The following is a description of a gene set: studied in species Homo sapiens Human Gene Set: GOBP_MRNA_TRANSPORT The directed movement of mRNA, messenger ribonucleic acid, into, out of or within a cell, or between cells, by means of some agent such as a transporter or pore., and this is the list of marker genes: NSUN2, FXR1, SARNP, NXF5, NUP160, SETD2, MX2, ZC3H11B, DDX25, NXT2, ALYREF, UPF3B, RANBP2, RAE1, NUP88, SMG6, LUZP4, NUP107, XPO1, SMG7, NDC1, UPF1, LRPPRC, PCID2, GLE1, RBM15B, EIF4A3, NXF2, FMR1, POLDIP3, NXF3, TNKS, AHCTF1, RANBP17, NUP85, DDX39B, IGF2BP1, HSF1, NUP54, NUP43, NUTF2, UPF3A (NCBI Gene Id 95832), POM121B, MAGOHB, KIF5C, NCBP1, SENP2, UPF2, NUP50, G3BP2 (G3BP stress granule assembly factor 2), PABPN1, DDX19A, ALKBH5, DHX9, SEH1L, THOC5, SEM1, NUP58, ZC3H3, NUP35, QKI, TPR, MVP, EIF4E, SMG5 (NCBI Gene Id 23381), NUP93, HNRNPA1, KHSRP, IWS1, RBM33, ZC3H11C, CETN2, NCBP2, FYTTD1, NUP214, NPIPA1, NXF2B, SRSF7, SMG1, NUP133, NUP42, DDX39A, MCM3AP, FXR2, BICD2, C12orf50, NCBP3, CHTOP, CETN3, MAGOH, THOC7, THOC1, THOC3, NXT1, HNRNPA1L2, YTHDC1, ZFP36, SEC13, NUP210, CASC3, NUP188, PEG10, NUP98, PARP11 (NCBI Gene Id 57197), NUP153, NUP205, ZC3H11A, WNK1, NUP62, AAAS (NCBI Gene Id 8086), NEAT1, SUPT6H, ZFP36L1, THOC6, SRSF3, NXF1, THOC2, IGF2BP2, SRSF1, HNRNPA2B1, RBM8A, AKAP8L, POM121, ARC, HHEX, POM121C, IGF2BP3, NUP155, DDX19B (NCBI Gene Id 11269), ENY2, NUP37 (NCBI Gene Id 79023), AGFG1, SLBP